The following is a description of a gene set: Human Gene Set: HP_LEFT_TO_RIGHT_SHUNT species: Homo sapiens Pattern of blood flow in the heart that deviates from the normal circuit of the circulatory system from the left side of the heart to the right. Left-to-right shunt, and this is the list of marker genes: TBX20, DBR1, GATA6, TLL1, MYH6, CITED2, THOC6, IFT56, NKX2-5, ACTC1 (NCBI Gene Id 70), GATA4